The following is a description of a gene set: species: Homo sapiens Human Gene Set: GOBP_COLUMNAR_CUBOIDAL_EPITHELIAL_CELL_MATURATION The developmental process, independent of morphogenetic (shape) change, that is required for a columna/cuboidal epithelial cell to attain its fully functional state. A columnar/cuboidal epithelial cell is a cell usually found in a two dimensional sheet with a free surface. Columnar/cuboidal epithelial cells take on the shape of a column or cube., and this is the list of marker genes: HIF1A (hypoxia inducible factor 1 subunit alpha), TMIGD1, PGR, BHLHA15, FZD5, GPAT4, HOXA5, XBP1, TGFB1, GATA2